Given this list of marker genes SDC1, VKORC1, BCO2, HSPG2, LRP12, TTPA, AKR1C4, PLB1, APOA4, LPL, APOC3, UBIAD1 (NCBI Gene Id 7801), LRP10, GPC3, AGRN, SDC3, BCO1, LRP1, GPC1 (glypican 1), GPIHBP1, GPC6, VKORC1L1, SDC4, AKR1C1, RBP2, AKR1C3, APOA1, RBP4, APOC2, APOM, GPC4, RBP1 (retinol binding protein 1), LRP2, RDH11, LDLR, APOE, APOA2, APOB, CLPS, GPC2, LRP8, LRAT, SDC2, RETSAT, AKR1B10, PNLIP, TTR, GPC5, here is a description of the gene set: species: Homo sapiens Human Gene Set: REACTOME_METABOLISM_OF_FAT_SOLUBLE_VITAMINS Metabolism of fat-soluble vitamins